The following is a description of a gene set: Congenital occlusion of a tube in the genital tract. Genital tract atresia studied in species Homo sapiens Human Gene Set: HP_GENITAL_TRACT_ATRESIA, and this is the list of marker genes: FREM1, FREM2, DYNC2LI1, ITGA8, FGFR2 (NCBI Gene Id 2263), TBX4, BBS12, GRIP1, KIF14, ARL6, RSPO2, WT1, POR, WNT3, GATA3 (GATA binding protein 3), MKKS, FRAS1, CCDC28B, BBS1